Given this list of marker genes MSRB3, MSRB2, MSRA, CYP1A2, CYP1B1, here is a description of the gene set: Sulindac metabolic pathway Human Gene Set: WP_SULINDAC_METABOLIC_PATHWAY species: Homo sapiens